Given this list of marker genes TRPM1, GRM4, GRM6 (NCBI Gene Id 2916), GRM8, GRM1, HOMER3, HOMER2, GRM5, FYN, GRM7, GRIK3, HOMER1, GRM3, GNAQ, GRM2, here is a description of the gene set: A G protein-coupled receptor signaling pathway initiated by glutamate binding to its receptor on the surface of a target cell, and ending with the regulation of a downstream cellular process. species: Homo sapiens Human Gene Set: GOBP_G_PROTEIN_COUPLED_GLUTAMATE_RECEPTOR_SIGNALING_PATHWAY